Given this list of marker genes SLC19A2, SLC25A32, SLC19A1, PDPN, SLC46A1, here is a description of the gene set: studied in species Homo sapiens Enables the transfer of folic acid (pteroylglutamic acid) from one side of a membrane to the other. Folic acid is widely distributed as a member of the vitamin B complex and is essential for the synthesis of purine and pyrimidines. Human Gene Set: GOMF_FOLIC_ACID_TRANSMEMBRANE_TRANSPORTER_ACTIVITY